Given this list of marker genes MFN1, PLEKHG1, SLCO5A1, CCDC47, UGT8, ANGEL2, GRID2, UTP3, TMTC1, SERINC3, SRP9, STXBP5 (NCBI Gene Id 134957), MBNL2, FAM133A, TRPC5, KLRD1, ANAPC1, TRA2B, ME1, LMCD1, C21orf91, SETD2, ZNF454, MIDEAS, NFKB1, AP1AR, EEA1, ADH5, SCN8A, DENND1B, PITX2, GABPA, TBCK, RGPD8, CDK6, DNAJB4, SPAG9, GCNT1, LANCL1, TRIM2, PGRMC2, PPP1R9A, HTR2C, MGARP, FAM135A, SNX30, MINDY2, SDE2 (NCBI Gene Id 163859), HOMER1, EIF2AK2, RIC1, SYNM, ARL6IP6, ALG11, PRPF40A, MIER3, CERS6, CFDP1, PPP1R2, BBX, GNAQ, IGSF3, SNAP91 (NCBI Gene Id 9892), ZRANB2, NUP54, DOLPP1, RNF138, GULP1 (NCBI Gene Id 51454), B3GALT5, HOOK3, PCDH11Y, POLR2H, PRELID2, ODAPH, DYNC1I2, ETF1, ZBTB25, TP53INP1, KIF20B, PRPF39, RICTOR, MAGT1, CRACD, ACBD5, BTG3, HLTF, EPB41L5, ADGRB3, SRSF3, BCL2L2, SREK1, C3orf38, PRKAA2, FGFR1OP2, CAMLG, RAP1A, PDE1C, CCNB1, MAP4K4, A1CF, SPDYE1, NOTCH2, PPP5C, ZNF326, SLU7 (SLU7 homolog, splicing factor), MIER1, ABCA5, FZD7, HECA, EXOC5, MTA1 (NCBI Gene Id 9112), PGAM1, CIAO2A, ZNG1A, LCOR, DUS4L, MED6, IKZF2, ABI3BP, FIGN, CLVS2, THSD7A, IKBIP, CFAP44, NAT1, SAMD8, KLF10, C6orf120, ACVR2B, CHST9, MZT1, COL11A1 (NCBI Gene Id 317718), EPHA3, LRRC4B, PCLO, SPATA6L, ZNF608, AHSA2P, TLCD4, PTGFRN, FGD4, RAB8B, COMMD3-BMI1, PRP4K, CSNK1D, TRPC1 (NCBI Gene Id 7220), GCC2, FSBP, ANKRD46, MTFR1, SESTD1, KRT28, PTBP3, CACUL1, NAA30, ANKRD22, UBA6, CAPN2, OGFRL1, MAP9, RMND5A, CSGALNACT2, ANKRD10, BBS10 (NCBI Gene Id 79738), PRRC1, GPR85, METTL6, PPARG, ARRDC4 (NCBI Gene Id 91947), UEVLD, TMED7, RGPD5, ADAMTS1, BRWD1, GSE1, STEAP2, ADAM22, NUP160, DIAPH3, CNTN1, LRP1B, GSTCD, TMEM65, MFSD8, PSMC2, ARFRP1, NDFIP2, GLIPR1, UGDH, LACTB2, GPR155, ANKRD26, TTC13, CCSER1 (coiled-coil serine rich protein 1), AFTPH, RFC3, CLDN12, TIFAB, TMEM255A, LRRTM3, ZBTB44, TMEM200A, ZBTB20, FZD3, TRAM1, CHRNA7, SMAD9, ACADL, PAPOLG, GUCY1A2, FNDC3B, SYTL5, SH3D19, RPS6KA5, SACS, FLRT3, ERC2, CCNY, HNRNPDL (heterogeneous nuclear ribonucleoprotein D like), ZNF652, ZNF792, CLCN4, GASK1A, LVRN, GOLGA6L2, ZDHHC21, GPALPP1, GPATCH11, LATS1, FEM1C, FBXL3, AGTR1, NEDD4L, S1PR1, PPHLN1 (periphilin 1), RBBP8, TPM3, SSR3, SCML2, CD163, ZNF148, RORA, BTG2, RRAGD, YIPF5, FMNL2, GATM, ZNF486, FNIP2, SNX16, NTF3, TXLNG, GTF3C3, EDIL3, ELL2, DHRS1, CBFB, BOD1L1, RAB27B, TCF12, SCARF1, TRUB1, SPOCK3, ATXN2, PDE4D, WDR26, ZC3HAV1L, DEFA6, AK3, FZD5, GPC6, TMEM167B, ZNF747, DAAM1, MTF1, FAM221A (family with sequence similarity 221 member A), MEIS2, WDR7, SERINC5 (serine incorporator 5), GPD2, MECP2, PDCD5, KLF7, SECISBP2L, CD99, EVI2A, TMEFF2, LIN7A, LSAMP, NOTUM, TRIM9, MIGA1, ZNG1B, SDC2, CHN1, KPNA4, CISD2, SEC24A, TNFRSF21, ARID2, HIPK1, ITGB6, CCDC179 (NCBI Gene Id 100500938), WAPL, UNC80, SMAD5, C11orf87, RIMOC1, PRKAG2, DNAJB14, ZNG1C, DCDC2, AQP3, ONECUT2, GRM5, SCAMP1, RHPN2, SIX4, FYB2, ZNF680, CMPK2, CRIPT, DDIT4, CCDC117, UBE2A, CAMSAP2, KATNBL1, SMG1, MTMR6, ASB3, AIDA, ARK2N, C9orf40, MEX3D, BEND7, BMI1, ZCCHC8, STYX, SEC22C, CCNG2, NUMB, MMP16, ZNG1F, HOXD13, HDAC9 (histone deacetylase 9), C5orf24, LACTB, ZEB2, ZBTB11, SFMBT1, CARF, RNF149, RALA, RHOQ, GRM7, GRIP1, TOLLIP, CCDC50, LARP4, KLF8, NR2C1, BRWD3, MBIP, GABRA4, WDR47, PTPRG, SCN3A, CYBRD1, ZDHHC15, PLEKHH2, URI1, NUP50, SCN1A, XPNPEP1, MYCN, PAQR9, ZFAND5, CTNNA3, ACAT2, CEP120, FGL2, PPEF2, SLC30A5, NCKAP1, TTC19, DIP2B, ITGAV, MAML1, RGS7BP, CA8, RGPD6, KCNJ3, LCTL, DTWD2 (NCBI Gene Id 285605), ARMCX3 (NCBI Gene Id 51566), TFAM, SOX5, NOS2, NDC1, IGF2BP3, MMUT, SUMF1, CCP110, SDF4, PIWIL3, REV3L, JARID2, MMD, ARL13B, ACTN4, FOXG1, NEGR1, PHYHIPL, TMTC3, SLC4A7, SFT2D1, U2SURP, MCF2L2, PREX2, GAPVD1, PPP1R27, RASSF8, ZBTB10, NAV2, SAMTOR, SF3A1, ACBD3, SLAIN1, TFDP3, ZBTB41, PAX5, PRKG1, NRXN1, SENP1, RESF1, FRMD5, ATP11A, SRSF6, NFAT5, RFX7, ZDHHC2, PROK2, AFDN, RC3H1, HMBOX1, POU2F1, PTPRR, RNF217, RGPD4, CFL2, CEP350, CACNA2D3, KIAA1586, ZNF503, BTF3L4, ZNF559, PRKAA1, DUSP7, GUCY1B1, FAM199X, BNIP3, NRG4, LPP, RO60, ZNG1E, APPBP2, SKIDA1, GABPB1, DPY19L3, RAP2A, TBCA, LRRC7, GOPC, ADAM30, ATXN7L1, RETREG1, MBNL3, METTL8, ZNF492 (NCBI Gene Id 57615), OAZ1, ADAMDEC1, SANBR, TMEM135, CBX3, MARCHF6, LMX1A, SLC24A3, PDZRN4, KL, MAST4, IGF1, MAST3, DYNC1LI2, PROSER1, MDFIC, PCDH11X, here is a description of the gene set: studied in species Homo sapiens from publication Chen Y, Wang X (PMID 31504780) Genes predicted to be targets of miRBase v22 microRNA hsa-miR-548o-5p, hsa-miR-548w in miRDB v6.0 with MirTarget v4 prediction scores > 80 (high confidence targets). Human Gene Set: MIR548O_5P_MIR548W